The following is a description of a gene set: species: Homo sapiens Human Gene Set: HP_MEMORY_IMPAIRMENT An impairment of memory as manifested by a reduced ability to remember things such as dates and names, and increased forgetfulness. Memory impairment, and this is the list of marker genes: EIF2B1, CCR1, TREM2, TMEM106B, RRM2B, FAS, TRAF7, MT-ND5, ATN1, TLR4, RNASEH1, PMS1, TUBG1 (tubulin gamma 1), GNAS, ARSA, PAH (NCBI Gene Id 5053), TREX1, MT-TS2, POLE, EPCAM, HCRT, POLD1, REEP2, STUB1, HLA-DRB1, USP8, PSEN2, ACSF3, ATXN3, NIPA2, CAMTA1, ERAP1, MEN1, IL10, TNFSF4, PDGFRB, MT-TF, MSH6, BRAF, CTSH, GNE, DNMT1, APP, PSAP, KDM1A, STAT4, SEMA4A, MMACHC, MT-CO1 (mitochondrially encoded cytochrome c oxidase I), ARMC5, PRKCG, IFNGR1, HTT, SLC20A2, VCP, MOG, PRORP, ZNF365, MT-TH, SQSTM1, MPV17, AFG3L2, MT-ND1, ABCD1, BAP1, NF1, SORL1, HMBS, AKT1, YY1, MT-ND4, UBAC2, PSEN1, PIK3CA, RPS20, CYLD, SLC25A13, P2RY11, CP, VAMP1, NOTCH3, PRNP, IL12A-AS1, MAPT, MT-TQ, HLA-DQB1, FMR1, MT-CO2, MYD88, MT-TL1, SPAST, SPG7, PMS2, BMPR1A, GSN, KLRC4, C4A, CDH23, BRCA2, MEFV, SMARCE1, CSF1R, MLH1, MT-CO3 (mitochondrially encoded cytochrome c oxidase III), APOE, GOSR2, TIA1, SUFU, SLC2A3, ATXN1, IL12A, ABCA7, EIF2B2, FGF14, PDGFB, HLA-B, NIPA1, ATRX, TTPA, AMACR, TRANK1, MYORG, PRKAR1B, TWNK, SPG11, USP48, MSH2, GRIN2A, TOMM40, XPR1, SMARCB1, ATM, IL23R, PIDD1, SIM1, CHMP2B, NPTX1, ADA2, POLG, MT-ND6, ECM1, KRAS, POU4F1, MUTYH, CHEK2, MT-TW, JPH3, GRN, NR3C1, TYROBP, ALDH18A1, SMO, TP53, TGFBR2, UGT1A1, NF2, TERT, SCO2